Given this list of marker genes Ncl, Secisbp2, Eif4a3l1, Eefsec, Rpl30, Eif4a3, Eif4a3l2, Secisbp2l, here is a description of the gene set: Mouse Gene Set: GOMF_SELENOCYSTEINE_INSERTION_SEQUENCE_BINDING species: Mus musculus Binding to a selenocysteine insertion sequence (SECIS), a regulatory sequence within mRNA which directs incorporation of a selenocysteine at a stop codon (UGA) during translation.